Given this list of marker genes PSAP, MFN2, NEFH, NOP56, HSPB3, ARSA, MPV17, HNRNPA2B1, TPP1, SCO2, GBF1, DYNC1H1, ERGIC1 (NCBI Gene Id 57222), ALS2, COL25A1, GDAP1, HNRNPA1 (NCBI Gene Id 780920), ACTA1 (actin alpha 1, skeletal muscle), CHCHD10, VCP, IGHMBP2, SPG7, ANO5, SPG11, TBCK, SYNE1 (NCBI Gene Id 85448), HSPB1, HINT1, PRPS1, HSPB8, PNPT1, SLC12A6, PLA2G6, UBA1, OPA1, SMN1, TBCE, IBA57, SCYL2, ASAH1, ATP7A (ATPase copper transporting alpha), MYH7, PLEKHG5, SMN2, NEB, LDB3, DCAF8, FBXO38, GJB1, SH3TC2 (SH3 domain and tetratricopeptide repeats 2), PMP22, VPS13A, VRK1, VAPB, here is a description of the gene set: EMG: neuropathic changes studied in species Homo sapiens The presence of characteristic findings of denervation on electromyography (fibrillations, positive sharp waves, and giant motor unit potentials). Human Gene Set: HP_EMG_NEUROPATHIC_CHANGES